The following is a description of a gene set: Microglossia species: Homo sapiens Human Gene Set: HP_MICROGLOSSIA Decreased length and width of the tongue., and this is the list of marker genes: GNAI3 (G protein subunit alpha i3), GLI3, SMO, ECM1, PTDSS1, EDN1, ROR2, LMNB2, NEK1, BMP4, PLCB4, MYMK, RBBP8, PRRX1, TBX15, DHCR7, TRIM37, OTX2